The following is a description of a gene set: Three innate (B1-B, NKT, CD8aaT cells) and adaptive (B2-B, CD4T, CD8abT cells) cell-types were sorted by FACS. Three biological replicates for NKT, CD4T, CD8aaT, CD8abT cells and two biological replicates for B1 and B2 cells were generated and the expression profiles were determined using Affymetrix Mu74Av2 chip. Comparisons between the sample groups allow the identification of genes differentially expressed between the innate and adaptive cell-types. Human Gene Set: GSE3039_CD4_TCELL_VS_NKT_CELL_UP from publication Yamagata T, Benoist C, Mathis D (PMID 16623764) studied in species Homo sapiens Genes up-regulated in CD4 T cells versus NKT cells., and this is the list of marker genes: GATA1, IRF9, PCMTD2, MTMR12, CELF2, ETHE1, OSBPL2, PLA2G2D, HECA, AP3M2, GRM1, CNTRL, BIN3, UBE2E2, C2orf88, PHKB, MLLT10, RICTOR, AKAP10, RAB37, PRG2, CREBRF, IKZF5, FGD4, FLACC1, LEF1, FBXO4, HOOK3, TNFAIP8L2, MDH1, SLC25A53, CCDC88A, RELA, SHLD1, RELB, TMUB2, HDAC4, GIMAP8, CCND3, SSH2, SHPRH, CREB1, CCM2, ENSG00000267882, AFMID, CYTIP, TRAF1, PDLIM2, HERPUD1, IQGAP1, ICAM1, SMIM14, MARCHF6, PAK1, PDCD4, MEPCE, IL4I1, WDFY2 (NCBI Gene Id 115825), HAUS8, PPP1R2P1, KRIT1, SCNN1A, GPD1, FSD2, ERMP1, STOM, ZEB1 (zinc finger E-box binding homeobox 1), OTULINL, MARVELD1, IVD, FCRLA, ARMC8, INSM1, FYCO1, CHST13, TMEM178A, CCL5, MLXIP, PIK3IP1, PDCD2L, VEZF1, RNASET2, ARRDC3, SZT2, PSENEN, VPS28 (NCBI Gene Id 51160), SLC2A4RG, KHK, CDKL4, UBAC2, RAB19, ST8SIA4, CGGBP1, CLK1, TEP1, MYO9A, PTCD2, P2RY13, FAM111A, GP2, YY1, TMEM150B, RBM48, GDI1, DOCK4, SENP6, ADCY3, HIPK3, SH2B3, UNC13D, ERICH3, SENP7, AMBRA1, EDRF1, NEDD4L, HNRNPH3, TESC, EVA1A, DENND1B, SLPI, CCDC125, PIKFYVE (NCBI Gene Id 387568), KIF21B, LTF, SKIC3, CDKN2AIP, EVL, RSRP1, CDS2, PDE2A, NDRG3, CCDC97, SEPHS2, LRP8, BTBD10, MKRN1 (makorin ring finger protein 1), STAT5B, GABPB2, P2RY10, LBH, CISD2, SAT1, ZDHHC7, ARHGAP17, SEPTIN9, RGS12, ARID4A, ZBTB32, ARID1A, DHRS7, MXD4, RNF144A, CDK19, PHACTR2, SH3BP1 (SH3 domain binding protein 1), CAMTA2, TAFAZZIN, NOTCH2, HEBP1, RAP1B, MBD4 (methyl-CpG binding domain 4, DNA glycosylase), ST3GAL4, ANKRA2, CCR9, DNAH8, PTS, ELMO2, IL6R, TAF5, RNF145, PDZD2, CDIPT, TGFB2, PIAS1, ANKLE2, NATD1 (N-acetyltransferase domain containing 1), ZNF571, UNC5CL, TUT4, INPP5K, RIT1, ABCC3, SYNE1, MTMR14, GANC, NR2C2, PARVG, BET1L, DCAF17, SMARCD2, DENND5B, B4GALNT1 (beta-1,4-N-acetyl-galactosaminyltransferase 1), SCYL3, FAM234B, P2RX1, PRICKLE2, NSMCE4A, NCOA2, VCL, B4GALT4